The following is a description of a gene set: Genes positively differentially expressed in cell type: cDC2 (conventional dendritic cell type 2) upon treatment with cytokine: IL-1α in mouse lymph nodes in vivo. Mouse Gene Set: CUI_CDC2_IL1A_RESPONSE_UP from publication Cui A, Huang T, Li S, Ma A, Pérez JL, Sander C, Keskin DB, Wu CJ, Fraenkel E, Hacohen N (PMID 38057668) species: Mus musculus Cytokines mediate cell-cell communication in the immune system and represent important therapeutic targets. A myriad of studies have highlighted their central role in immune function, yet we lack a global view of the cellular responses of each immune cell type to each cytokine. To address this gap, the authors created the Immune Dictionary, a compendium of single-cell transcriptomic profiles of more than 17 immune cell types in response to each of 86 cytokines (>1,400 cytokine-cell type combinations) in mouse lymph nodes in vivo. A cytokine-centric view of the dictionary revealed that most cytokines induce highly cell-type-specific responses. For example, the inflammatory cytokine interleukin-1β induces distinct gene programmes in almost every cell type. A cell-type-centric view of the dictionary identified more than 66 cytokine-driven cellular polarization states across immune cell types, including previously uncharacterized states such as an interleukin-18-induced polyfunctional natural killer cell state., and this is the list of marker genes: Slc33a1, Marcks, Cxcl16, Zfp263, Ankrd33b, Rap2a, Basp1, Prpf31, Arhgap30, Ier3, Pdcd6ip, Irs2, Vmp1, Cdc34, Diaph1, Cd164, Zfand6, Aebp2, Rftn1, Fnbp1l, Plekha3, Fbxo32, Socs2, Ccdc71l (coiled-coil domain containing 71 like), Prdm1, Zfp106, Mbtd1 (NCBI Gene Id 217110), Tmbim1, Ptpn2, Psme2 (NCBI Gene Id 19188), Ptpn1, Hemk1, Gyg1, Tle3, Etv3, Eif1, Nup88, Il21r, Rpain, Slc14a1, Plxna1, Smarce1, Ffar2, Coro2a, Gfra2, Wnk1, Cnn3, Alkbh6, Samsn1, Lsm12, Glipr2, Iscu, Atp11a, Arfgap3, Med15, Ewsr1, Batf3, Pde4b, Tnfrsf18 (tumor necrosis factor receptor superfamily, member 18), Vdr, Got1, Slc2a1, Sinhcaf, Rab8b, Kmo, Rabgap1l, Nr4a3, Litaf, Arhgap31, Traf6, Fyn, Ehd1, Aars1, Mt1, Ahcyl2, Csnk1d, Parl, Dennd4a, Mif4gd, Flot1, Birc2, Rasgrp1, Fscn1, Adora2a, Psma3, Icam1, Hnrnpll, Nck2, Spred1, Myl6, Psmc4, Elp5, Ccr7, Cd53, Cacnb3, Arfgap2, Tpm4, Irf5, Rassf2, Gabarap, Cflar, Hif1a, S100a4, Slc26a2, Kdm2b, Atp2b4 (ATPase, Ca++ transporting, plasma membrane 4), Tnfrsf4, Tet2 (tet methylcytosine dioxygenase 2), Suox (sulfite oxidase), Cdkn1a, Ccnd2, Il1b, Trpv2, Mir155hg, Stat5a, Golgb1, Gcnt2, Plet1, Cd86, Btg1 (BTG anti-proliferation factor 1), Snn, Cd80, Sdc4, Ass1, Mrps6, Ccser2, Srsf2, Bhlhe40, Dnajb6, Sphk1, Cyrib, Eif6, Rbm3, Aldh1a2, Rbbp6, Dab2, Myh9, Polr2a, Fem1c, Nras, Mdh2, Car2, Riok3, Mrpl20, Cyth1, Sav1, Chchd4, Tmem39a, Sumo2, Gnb4, Ranbp2, Fabp5, Socs3, Fchsd2, Rab14, Mmp25, Mfhas1, Fcho2, Hax1, Tmem131, Fbxo11, Ywhaq, Tbc1d15, Lgmn, Tmed5, Cd209e, Klf7, Krcc1, Anxa7, Ddx6, Med21, Map4k4, Tspan3, Mt2, Adam19, Lmnb1, Rgs1, Lad1, Vti1a, Huwe1, Car13, Rabep1, Slc7a11, Il7r, Tuba1b, Zbtb18, Nfkbia, Cst3, Ube2h, Mapre1, Anxa3, Rai14, Zfp366, Csf2rb, Il1rn, Sfpq (NCBI Gene Id 78315), Cd63, Ggta1, Adgrg6, Mllt6, Eif5a, St7, Ly75, Gpr183, Arih2, Trim25, Ccl22, Madd, Txnrd1, Cldnd1, Gpr132, Itgb1, Pcgf5, Il4i1, Bmp2k, Pla2g15, Mvp, Zfand3, Snx3, Rab27a, Castor2, Tnfrsf11a, Gnai3, Pim1, Ube2l3, Dennd5a, Vgll4, Lilrb4b (leukocyte immunoglobulin-like receptor, subfamily B, member 4B), Dnajc10, Ndrg1, Psmb4, Plk2, Hipk2, St6gal1, Cfp, Uap1, Casp8, Zfc3h1, Spint2, Selplg, Plscr1, Sec11a, Trip12, Cd209c, Xxylt1, Traf1, Pik3r5, Ext1, Galnt7, Rel (reticuloendotheliosis oncogene), Marcksl1, Scn3a, Tmtc3, Tmem63b, Tax1bp1, N4bp2l1, Cdk6, Pnpla8, Stat4, Arl5a, Arpc2, Cfl1, Ddit4, Prps1, Pgs1, Orai1, Pfn1, Stard7, Kdm6b, Etv6, Nfkbib, Oasl2, Hsd11b2, Picalm, Nfil3, Adpgk, Vcp, Sf3b3, Nipal1, Pnp, Il4ra (NCBI Gene Id 16190), Tuba1c, Bcl2l1, Gimap1, Odc1, Arap2, Naaa, Sdhaf1, Syngr2, S100a11, Sh3bgrl, Mrc1, Sipa1l3, Nckap1l, Aff1, Stat3, Slamf1, Wdr1, Ptpn4, Anxa2, Nfkb2, Map3k14, Nuak2, Cytip, Tspan13, Dusp2, Eloc, Aamp, Vim, Hsf2, Mkln1, Psmd11, Scd1, Ciao2b, Wipf1, Kdm5c, Dcun1d3, Nfat5, Timd4, Bcl2a1a, Palld, Gramd4, Runx3, Enah, Cish, Atp1a1, Slc30a4, Pnrc1, Relb, Adcy6, Noct, Tbc1d4 (NCBI Gene Id 545073), Pdcd1lg2 (NCBI Gene Id 58205), Ak2, Rufy3, Foxn3, Psmb7, Camk2g, Cox17, Bach1, Crem (cAMP responsive element modulator), Pkib, Tes, Dnajb9, Siglecg (sialic acid binding Ig-like lectin G), Rab21, Creb5, St3gal4, Bzw2, Rtn4, Scimp, Nfya, Thada, Myo1g, Acvr2a (NCBI Gene Id 11480), Actn1, Kcnk6, Malt1, Ccl17, Serinc5, Jaml, Uck2, Fosl2, Ikzf4, Klf9, Ywhae, Bcl2a1b, Bcl3, Fkbp5, Eif4e, Idi1, Arl8b, Ost4, Plekha1, Dusp5, Tarm1, Rspry1, Prkcd, Gatm, Nudt17, Necap2, Cdh1, Rcl1, Lrrc8c, Srgn, Sar1a, Snd1, Snap23, Strip2, Adprh, Sh3pxd2b, Chd7, Eif1ax, Ncl, Ctsz, Serpina3g, Fabp4, Ktn1, Id1, Actg1, Serpinb9, Nrp2 (neuropilin 2), Tmem131l, Cnn2, Ric1, Ramp3, Spint1, Gpr171, Adam8, Abracl, Ptger4, Ccdc102a, Slfn2, Cd274, Clic4, Pfkp, Clec4n (NCBI Gene Id 56620), Kif1a, Hnrnpk, Prnp, Arid5a, Bcl2a1d, Myl12a, Ms4a4c, Arpc5, Hs3st3b1, Sema7a, Tmem127, Prkar1a, Cct3, Cd83, Birc3, Edem1, Lima1, P2ry10, Pacsin2, Wtap, Gnb1, Htr7, Nectin2, Pik3r1 (phosphoinositide-3-kinase regulatory subunit 1), Ap2s1, Tubb6, Stxbp6, Chp1, Tnip2, Nfkb1, Bcl7c, Poglut1, Chchd2, Fcgr2b, Hspbap1, Il2ra, Tmem123, Mkrn1, Ch25h, Xbp1, Hbegf, Lrrk1 (leucine-rich repeat kinase 1), Tagln2, St8sia4, Rgs12, Socs1, Gpat4, Csde1, Psma6, Dynlrb1, Pde1b, Ifitm1, Il6 (interleukin 6), Id2, Stk39, Pogk, Cdk2ap2 (NCBI Gene Id 67777), Jak2, Serpinb6b, Kif3b, Rbm47, Hnrnpa3, Gpr146, Cpeb2, Csrp1, Gpbp1, Bclaf1, Pmvk, Ms4a6d, AA467197, Dok2, Mapkapk3, Gadd45b, Ifitm2, Apobec3, Rras2